Given this list of marker genes BMP5, TKT, CLCN2, PDXK, TPI1, WNT4, PNPO, CACNA1H, KDM3A, BMP6, CYP11B1, PCK1, DKK3, DAB2, SLC25A10, BMP2, REST (NCBI Gene Id 5978), CYP11B2, here is a description of the gene set: species: Homo sapiens The chemical reactions and pathways resulting in the formation of aldehydes, any organic compound with the formula R-CH=O. Human Gene Set: GOBP_ALDEHYDE_BIOSYNTHETIC_PROCESS